Given this list of marker genes TRIM26, KCND1 (NCBI Gene Id 3750), AGO1, NOS1, FAM53A, RASSF4, SATB1, STEAP2, NQO1, MAFG, YTHDF3, SUSD6, DGKI, SH3GL2, LUZP1, REG3G, PPM1M, AIF1L, GRM2, NFX1, RGMB, RIMS2 (NCBI Gene Id 9699), SOX10, C17orf67, MAP3K11, ATP2B4, KLHL14, DCX, BTN2A2, AK3, DGKK, SLC37A1, XYLT1, ANKFY1, FAM78A, SLC10A7, ARHGEF6, TRIM46, TMEM217, STK35, SDC3, ETV4, HNRNPR, SCML1, ERG28, TRIM35, SLC6A17, LDLRAP1, SSR1, PARP6, STAB2, PIANP, FNDC3B, N4BP1, VPS39, COL16A1, TMEM201, CDIN1, CHAF1A, PRMT6, PRR32 (proline rich 32), NOTCH2, ZNF862, CERS3, SMARCD1, NEUROD4, LSM12 (NCBI Gene Id 124801), COL5A3, SHOC1, CDON, KBTBD2, DUSP13A, GABRA4, MORN5, KCNIP1, TCEA2, SRGAP2, TRIM4, NCAPH, ADAMTS4, RHBDL1, ST3GAL5, WASF2, TENT4A, KCNB1 (potassium voltage-gated channel subfamily B member 1), GOSR2, KIAA0513, NAV1, MAPKAPK2, KCNJ6, AMOT, PUM2, FHL1, TLL2 (tolloid like 2, NCBI Gene Id 7093), ANKRA2, ACVR2B (activin A receptor type 2B), RAB1B, TSPAN9, ZNF385A (zinc finger protein 385A), CLIC5, IKZF1, RTKN, CECR2, RNF19B, KIF21B, NFYA, PAX5, WDTC1, HR, USP7, here is a description of the gene set: from publication Chen Y, Wang X (PMID 31504780) Genes predicted to be targets of miRBase v22 microRNA hsa-miR-4436b-3p in miRDB v6.0 with MirTarget v4 prediction scores > 80 (high confidence targets). Human Gene Set: MIR4436B_3P species: Homo sapiens